Given this list of marker genes UBE2J1, EPCAM (epithelial cell adhesion molecule), MAFG, PTPRC, JCHAIN, FLI1, SLA, TRIB1, IL27RA, ZNF804A, PMF1, ITGB7, ATF4, LY9, CERS2, CEBPG, CCN4, COPZ2, PDIA6 (protein disulfide isomerase family A member 6), ST6GAL1, DDIT3, SOHLH2, IQGAP2, TXNDC15, STAG2, ZEB2, DDIT4, CYTIP, S100A11 (NCBI Gene Id 6282), CBS, SLC7A11, TRAF3IP3, FAM149A, NR3C1 (NCBI Gene Id 389335), FGFR3, SCD, DNAJB1, PDE3B, CAPN2, HOMER3, CD79B, CCDC69, QPCT, ITGB5, ANP32B, CDK14, NSD2 (NCBI Gene Id 7468), FXYD5, E2F2, CD58, CHAC1, HMOX1, SUMO3, KLHL21, PMM2, TLK1, ST7, GSTO1 (glutathione S-transferase omega 1), BHLHE40, SMYD5, DNAJB9, GSDMB, THUMPD2, NFIC, CCND1, TNS3, NOL12, HERC4, MYB, DST, TSHR (NCBI Gene Id 7253), FAIM, INHBE, CLIC2, SLC38A1, RPL10, MYBL2, TAPBPL, CLEC2B, IFI16, ISG20, ELF1, LSAMP (NCBI Gene Id 4045), SLC3A2, DNAJB4, MZF1, DNAJC15, CADM1, CHST15, TXNDC5, PPP1R16B, TIMM44, HSPH1, PIM2, LIMD2, PRSS3P2, LRRC41, DEPTOR, OAS2, LONP1, PSAT1 (NCBI Gene Id 29968), DESI2, HNRNPUL1, MBNL1, SELPLG, SETBP1, EHD3, CD180, GUCY1A1, P2RX5 (NCBI Gene Id 5026), ILF3, FERMT1, TCF4, MFNG, SYNE3, OLR1, ZHX2 (NCBI Gene Id 22882), AVEN, NUAK1, KCNK1, PHF11, CASP1, RHOBTB1, EYA2, CCPG1, IFNAR2 (NCBI Gene Id 3455), AUTS2, ECPAS, MARCHF6, ZMYND8, SNTB1, EIF5, MYCN, ITGA4, BTN3A2, TMPRSS15, NFE2L1, CLEC7A, TNFRSF10D, LAPTM5, PDE4D, PHACTR2, ST14, ZNF532, TYMS, RASGRP3, PRTN3 (proteinase 3), PLCL2, SUCLG2, CLK1, GGT1 (gamma-glutamyltransferase 1), PKD1, MAFF, KCNN3, UCK2, TNFRSF17, HSPE1, ENSG00000293341, ALDH3B1, CEACAM1, LRP8, PITX1, SNHG32, JMJD1C, BCL3, SLC25A51, CCR2, CEBPB, HGF, BCL2, IRF4, SLC1A4, CD28, IFRD1, TRIB3 (tribbles pseudokinase 3), MYC, HSPA9, HDGF, CFLAR, ALG8, IGKC, HSPA1B, BCL2L1, CELF2, CYC1, FKBP11, HSPA1A, KIZ, HSP90B1, DUSP6, TNFRSF14, CILK1, SPCS2, WNT5B, PPRC1, UBE2E1, KIAA1549L, LY96, HERPUD1, BAG3, CBR3, GDF15, SLC7A5, SH2D1A, NSMAF, PDK1, MYOM2, SRM, TPP1, MYCL, GAS2, ST3GAL6, CDKN1B, HSPA6, OGT, SRSF7, PSMB10, POU2AF1, FARP1 (FERM, ARH/RhoGEF and pleckstrin domain protein 1), MAGEH1, SLC47A1, SULF1, SERPINH1, CCR1, BLNK, FAS, MAPK13, DNAJB12, PPP1R15A, ZMIZ1, FNDC3A, OAS1, IL6R, CDKN2C, USF2, IRAG2, ATF3 (NCBI Gene Id 467), HSPD1, MAP4K1, GALNT14, FMNL1, NUP210 (NCBI Gene Id 79985), SLC25A15, POLR3E, SHMT2, NIBAN1, RBM3, XBP1, IL21R, IRF8, RAB15, ATF5, MRPS15, VEGFA, HSPB1, MAF, CD48, LRP2BP, ANK3, DCPS, HBG1, HBD, SRSF8, ADCYAP1, GJA1, ZBTB38, SEC24D, PXDN, CDKN2A, HBB, STAT6 (signal transducer and activator of transcription 6), IGF2BP3 (NCBI Gene Id 10643), IRAK1, DOCK10, CCND2, ZNF280D, SDC1, GADD45A, PITPNC1, WIPF1, PFAS, here is a description of the gene set: from publication Heller G, Schmidt WM, Ziegler B, Holzer S, Müllauer L, Bilban M, Zielinski CC, Drach J, Zöchbauer-Müller S (PMID 18172295) studied in species Homo sapiens Human Gene Set: HELLER_HDAC_TARGETS_SILENCED_BY_METHYLATION_DN To identify epigenetically silenced cancer-related genes and to determine molecular effects of 5-aza-2'-deoxycytidine (Aza-dC) and/or trichostatin A (TSA) in multiple myeloma (MM), we analyzed global changes in gene expression profiles of three MM cell lines by microarray analysis. We identified up-regulation of several genes whose epigenetic silencing in MM is well known. However, much more importantly, we identified a large number of epigenetically inactivated cancer-related genes that are involved in various physiologic processes and whose epigenetic regulation in MM was unknown thus far. In addition, drug treatment of MM cell lines resulted in down-regulation of several MM proliferation-associated factors (i.e., MAF, CCND1/2, MYC, FGFR3, MMSET). Ten Aza-dC and/or TSA up-regulated genes (CPEB1, CD9, GJA1, BCL7c, GADD45G, AKAP12, TFPI2, CCNA1, SPARC, and BNIP3) were selected for methylation analysis in six MM cell lines, 24 samples from patients with monoclonal gammopathy of undetermined significance (MGUS), and 111 samples from patients with MM. Methylation frequencies of these genes ranged between 0% and 17% in MGUS samples and between 5% and 50% in MM samples. Interestingly, methylation of SPARC and BNIP3 was statistically significantly associated with a poor overall survival of MM patients (P = 0.003 and P = 0.017, respectively). Moreover, SPARC methylation was associated with loss of SPARC protein expression by immunostaining in a subset of MM patients. In conclusion, we identified new targets for aberrant methylation in monoclonal gammopathies, and our results suggest that DNA methyltransferase and histone deacetylase inhibition might play an important role in the future treatment of patients with MM. Genes down-regulated in multiple myeloma (MM) cell lines treated with both decitabine TSA.